The following is a description of a gene set: species: Mus musculus Genes positively differentially expressed in cell type: γδ T cell upon treatment with cytokine: CD40L in mouse lymph nodes in vivo. Cytokines mediate cell-cell communication in the immune system and represent important therapeutic targets. A myriad of studies have highlighted their central role in immune function, yet we lack a global view of the cellular responses of each immune cell type to each cytokine. To address this gap, the authors created the Immune Dictionary, a compendium of single-cell transcriptomic profiles of more than 17 immune cell types in response to each of 86 cytokines (>1,400 cytokine-cell type combinations) in mouse lymph nodes in vivo. A cytokine-centric view of the dictionary revealed that most cytokines induce highly cell-type-specific responses. For example, the inflammatory cytokine interleukin-1β induces distinct gene programmes in almost every cell type. A cell-type-centric view of the dictionary identified more than 66 cytokine-driven cellular polarization states across immune cell types, including previously uncharacterized states such as an interleukin-18-induced polyfunctional natural killer cell state. from publication Cui A, Huang T, Li S, Ma A, Pérez JL, Sander C, Keskin DB, Wu CJ, Fraenkel E, Hacohen N (PMID 38057668) Mouse Gene Set: CUI_T_CELL_GD_CD40L_RESPONSE_UP, and this is the list of marker genes: Tubb4b, Trac, Cd82, Tmbim6, Pfn1, Cyba, Rnase4, Calr, Egln1, Rorc, Gpbp1, Snrpa, Ybx1